The following is a description of a gene set: from publication Amit I, Garber M, Chevrier N, Leite AP, Donner Y, Eisenhaure T, Guttman M, Grenier JK, Li W, Zuk O, Schubert LA, Birditt B, Shay T, Goren A, Zhang X, Smith Z, Deering R, McDonald RC, Cabili M, Bernstein BE, Rinn JL, Meissner A, Root DE, Hacohen N, Regev A (PMID 19729616) Genes up-regulated in comparison of dendritic cells (DC) stimulated with Pam3Csk4 (TLR1/2 agonist) at 0.5 h versus those stimulated at 24 h. Human Gene Set: GSE17721_0.5H_VS_24H_PAM3CSK4_BMDC_UP mouse primary BMDCs were stimulated with tlr ligands and gene expression changes were profiled on Affymetrix arrays species: Homo sapiens, and this is the list of marker genes: PPARG, YWHAH, RWDD1, ZW10, PRRC1, SMC3, POLE3, UBE2G2, PGLYRP1, PLAAT3, S100A1, PPIB, CBX6, GJD2, TRAM1, SEC16B, USP7, WDSUB1, AP3D1, VRK3, RTTN, SH3BP5L, NFATC2IP, REXO1, ARF5, DDR2, RELN, POM121, INSL6, RPP40, MRPL2, EEF1B2, METAP2 (methionyl aminopeptidase 2), DNAJC2, DDX39B, KDR, RASGRP4, IL2, HSPBP1, NR2F6, CSK, TTC13, ELOVL1, PMM2, DNAJC3, DUSP10, LARP7, FARSA (phenylalanyl-tRNA synthetase subunit alpha), PRR15, TNFRSF9, RPN1, IDH3A, SLC7A8, DCAF4, PTGER4, MIEN1 (migration and invasion enhancer 1), NDUFB5, BTC (NCBI Gene Id 685), SCAF8, MVP, IGF2R, PTPN2, RRN3, TMEM53, JUN, TOMM40L, PELO, KCNU1, R3HCC1, S100A13, HOMER1, PSME1, FKBP1A, GNG10, CLEC6A, SLC52A2, ARPC5, SLC12A7 (solute carrier family 12 member 7), ARHGAP1, TF, PADI4, CD244, ZFP64, HDAC3, MIDN, RELL1, TREX1, GDAP2, PIGA, RPL13, ZFP90, HIVEP1, PIGX, CCNH, SNX3, GRSF1, CNP, PA2G4, PPP1R17, RPS11, PLCG2 (phospholipase C gamma 2), FGF18, RASSF8, SCGB3A2, ALDH18A1, SND1, PLA2G15 (NCBI Gene Id 23659), ACAA2, ALDH1A2, PIGO, STEAP3, NIPA2 (NIPA magnesium transporter 2), MCUB, AXIN2, GTF2F1, RNF34, DNPEP, DDX54, C1D, GLRX3, MDH2, LYPLA2, SCAND1, LARP1, DIABLO, TMEM51, EHBP1L1, SAAL1 (NCBI Gene Id 113174), PTPN9, MUC1, HEBP2, TIAM1, SLC38A3, GALM, LSM7, MBD1, ENDOD1, EPS15L1, ANAPC5, NUDT16L1, VIM, CCL24, SHE, DNAJC5, ABHD2, CAPN2, COMT, ELP1, TSPAN14, HECTD3, AURKA, AFG1L, DUT, SCAMP2, HBEGF, PIP5K1C (NCBI Gene Id 23396), SLC35F6, COQ5, IL7R, MXD1, LAPTM4B, EEF1AKMT1, NRTN, PBDC1, DOCK1, PI4KA, HLA-E, SLC25A3, UQCRC2, RAB5IF, DUS1L, TAS2R1, MEF2C, SSBP4, NDUFA5, SELPLG, RPS21, COX5A, ZBTB45, HNRNPF, PNPO, ARF6, EI24, TSR1, RTP4, IFI27L2, GTF3C5, ATP5PO, BIN3, ATF1, MFAP1, EID1, H2AC25, SERPINF1, PLEKHF1, ATP6V1B2, UAP1L1, ABCG1, EVI5, EIF5A